Given this list of marker genes KLRC2, HLA-F, AP1G1, LAMP1, CD160, here is a description of the gene set: Any process that modulates the frequency, rate, or extent of natural killer cell degranulation. species: Homo sapiens Human Gene Set: GOBP_REGULATION_OF_NATURAL_KILLER_CELL_DEGRANULATION